Given this list of marker genes NEIL1, POLB, PARP2, PARP1, NEIL2, PNKP, NEIL3, XRCC1, TDP1, here is a description of the gene set: species: Homo sapiens Base excision and strand cleavage by NEIL glycosylase. Pathway ID: N01435. Pathway type: Reference. Pathway class: nt06504 Base excision repair. Human Gene Set: KEGG_MEDICUS_REFERENCE_BASE_EXCISION_AND_STRAND_CLEAVAGE_BY_NEIL_GLYCOSYLASE Pathway Definition from KEGG: glycosylase -> TDP1+PNKP == POLB+XRCC1 == PARP